The following is a description of a gene set: studied in species Homo sapiens Human Gene Set: GOBP_ANTIGEN_PROCESSING_AND_PRESENTATION_OF_PEPTIDE_ANTIGEN The process in which an antigen-presenting cell expresses peptide antigen in association with an MHC protein complex on its cell surface, including proteolysis and transport steps for the peptide antigen both prior to and following assembly with the MHC protein complex. The peptide antigen is typically, but not always, processed from an endogenous or exogenous protein., and this is the list of marker genes: RAET1E, PIKFYVE, CTSL, TAPBPL, ERAP2, MFSD6, CTSD, CLEC4A, HLA-B, TAP1, MR1, B2M, FCGR1A, ERAP1, FCER1G, RAET1L (retinoic acid early transcript 1L), LGMN, HLA-C, PDIA3, MARCHF1, ABCB9, HLA-A, HLA-DQA2, HLA-H, TRAF6, MPEG1, IFI30, HLA-G, HLA-DMA, CTSV, ULBP2, HLA-DMB, HLA-DQA1, TAPBP, HFE (NCBI Gene Id 3077), HLA-DQB1, ULBP3, HLA-F, HLA-DRB3, IKBKB, CD74, CLEC4M, SLC11A1, PYCARD, AZGP1, CTSF, TREM2, CTSS, FCGR2B, HLA-DRB1, CTSE, HLA-DRB5, DNM2, MARCHF8, HLA-E, HLA-DPA1, CD209, LNPEP, IDE, HLA-DOB, ACE, HLA-DOA, TAP2, HLA-DQB2 (major histocompatibility complex, class II, DQ beta 2), CALR, ULBP1, HLA-DPB1, RAET1G, HLA-DRB4, UNC93B1, SAR1B, HLA-DRA